The following is a description of a gene set: To define the ECM composition of tissues and tumors, we have empolyed a proteomics-based method to enrich and identify ECM proteins and coupled it with a bioinformatic annotation of the matrisome defined as the ensemble of ECM and ECM-associated proteins. To identify ECM proteins important for breast cancer progression and metastasis formation, we used a xenograft model where human breast cancer cells of differing metastatic potenital were orthotopically injected into the mouse mammary fat pad. The poorly metastatic MDA-MB-231 cell line was established from cells isolated from a sample from a triple-negative breast cancer patient. The highly metastatic MDA-MB-231-LM2 line (denoted LM2), was previously selected and characterized for increased metastatic potential to the lungs. 6.5 weeks post-injection, the primary tumors were harvested, ECM proteins were enriched from tumors, and the composition of the ECM-enriched fractions obtained was characterized by mass spectrometry. We define the matrisome of a tumor as the ensemble of proteins detected in two independent biological replicates and by at least two peptides in one of the two replicates. Using this proteomics approach we show that both the tumor cells and the stromal cells contribute in characteristic ways to the production of the tumor ECM. Moreover, we show that both tumor- and stroma-derived proteins differ between tumors of different metastatic potential. Comparison of the matrisomes of MDA-MB-231 tumors and LM2 tumors identifies ECM proteins characteristic of poorly and highly metastatic tumors. This gene set lists the matrisome proteins secreted by the tumor cells and stromal cells in MDA-MB-231 tumors and not from LM2 tumors. species: Homo sapiens Human Gene Set: NABA_MATRISOME_POORLY_METASTATIC_BREAST_CANCER from publication Naba A, Clauser KR, Lamar JM, Carr SA, Hynes RO (PMID 24618895) Matrisome proteins exclusievly detected in poorly metastatic breast cancer human-to-mouse xenografts (MDA-MB-231) in comparison to highly metastatic breast cancer human-to-mouse xenografts (MDA-MB-231_LM2)., and this is the list of marker genes: THBS2, TIMP3, S100A16, MMP19, ASPN, LAMA2, PRELP, S100A8, NGLY1, FBLN5 (fibulin 5), COL19A1, VWA1, TNXB, COL28A1, COL6A6, OGN, ITIH3, FLG2, COL26A1, COL17A1, HMCN1, LUM, PLAT, MMP1, EMILIN2